Given this list of marker genes PGS1, OSGIN2, LDHA, EIF5B, FURIN, HIF1A, CTBS, FTSJ1, ARL1, PDE12, CASP4, C18orf21, AHNAK, SLC66A2, NDUFS6, GPSM1, NOP58 (NOP58 ribonucleoprotein), TXNDC16, CARM1, FNTB, MTG1, AMACR, NRAS, AGPAT3, TNFAIP8, CD27-AS1, STING1, KIF2A, CSTPP1, BATF, VPS50, B3GNT2, PDE4B, MAFF, ARL4C, GLRA1, SDHAF2, VRK2, NUP37, GPR35, MRPS11, IDH1, CYFIP2, TBC1D1, ALS2 (alsin Rho guanine nucleotide exchange factor ALS2), CA2, CCND2, IL2RB, ZBTB22, PNP, SFMBT2, AQP9, JTB, LDAF1 (lipid droplet assembly factor 1), ARF6, GOLPH3L, MTFMT, DZIP1, INTS12, R3HDM1, RBL1, SNAP29, SLC39A1, TTYH2, COX18, ARC, NDST1, TRIM25, BCL3, RAF1, IL17RA, SDF4 (NCBI Gene Id 82832), VPS26C, EQTN, TNIP2, ATG16L1 (NCBI Gene Id 81560), BTF3, CHRDL1, EIF5A, SOCS3, CLCC1, JAK2, CD200, PRDM1, RNF10 (NCBI Gene Id 9921), OGFR, RMDN3, SYCP1, APEX2, PRAF2, EIF1AY, DCUN1D5, HELZ2, OXR1 (oxidation resistance 1), PARP4, STARD3, MS4A6A, SYS1, MTARC2 (mitochondrial amidoxime reducing component 2), ZNF346, LYST, RAB18, EBP, UBXN8, IPP, TAF11, APOBEC1, DAO, CYTH1, MTREX, GATA1, SGK1, SLC25A17, ADAM19, RAP2A, MND1, CS, STT3B, ZC3H12A, MCM3, PUF60, MAFK, TFDP1, GPR146, B3GNT3, CEP70, MDK, AKAP12, ZFP1, OSBPL9, TOR1AIP2, ATP2C1, NAMPT, NCBP3, ATOSB, PARP9, CDC42SE2, CAND1, GPR180, ADSS2, MRPS26 (NCBI Gene Id 81568), AAR2, TPP2, CREBRF, NCOA1 (NCBI Gene Id 8648), SH3BP5, MCM4, PDE8A, DENND5A (DENN domain containing 5A), TECTA, RAB29, SORD, CHFR, RNF157, PDSS1, DNAJC10, FAM83F, DNAJA2, GM2A, GPR65, MLLT3, IRF4, GLCCI1, RNF19A, EIF2AK4, ODR4, FGF11, SERPINB9, ANGPT2, PSMB8, ASAP1, CLIC4, RGR, TRAF3IP2, IKZF2, CRTC3, TBK1, PRPF31, ZNF281, RNF14, CRLF2, PNPLA2, APLP2, MRPL42 (NCBI Gene Id 64974, mitochondrial ribosomal protein L42), ADGRF1, C19orf12, STXBP3, EEIG1, UVRAG, CMTM6, SLAMF1, OSGEP, C9orf85, SAMHD1, IFI35, GSAP, FRMD6, BCKDHB, DPM1, TLR1 (NCBI Gene Id 7887), here is a description of the gene set: Genes down-regulated in lymphoid-primed multipotent progenitors versus pro-B lymphocytes. Regulation of lineage potential and transcriptional priming by Ikaros. New insight is provided into a bivalent regulation of lineage priming in the HSC and its lympho-myeloid restricted progeny the LMPP by the lymphoid lineage-determining factor Ikaros Whereas Ikaros is responsible for the activation of a cascade of lymphoid expression programs and for the establishment of lymphoid potential from the HSC to the LMPP it is also responsible for the repression of stem cell and erythroid genetic programs that are incompatible with further lineage restrictions emanating from the LMPP Human Gene Set: GSE15330_LYMPHOID_MULTIPOTENT_VS_PRO_BCELL_DN studied in species Homo sapiens from publication Ng SY, Yoshida T, Zhang J, Georgopoulos K (PMID 19345118)